The following is a description of a gene set: VEGFR1 specific signals Human Gene Set: PID_VEGFR1_PATHWAY studied in species Homo sapiens from publication Schaefer CF, Anthony K, Krupa S, Buchoff J, Day M, Hannay T, Buetow KH (PMID 18832364), and this is the list of marker genes: CD2AP, CAV1, PDPK1, HSP90AA1 (heat shock protein 90 alpha family class A member 1), NCK1, RASA1, AKT1, VEGFB, PRKACA, MAPK3, HIF1A, PLCG1, VEGFA, CBL, NOS3, FLT1 (fms related receptor tyrosine kinase 1), NRP1, PIK3CA, PIK3R1, PRKCA, MAPK1, SHC2, PTPN11, PRKCB, NRP2, PGF